Given this list of marker genes PLA2R1, KRT12, UGGT1, AGGF1, ZNF549, MALT1, LPAR3, EN2, APPBP2, XAB2, ZNF606, STS, CENPJ, HAND2, AGT, TULP2, DHX58, MAPK1, PIK3IP1 (phosphoinositide-3-kinase interacting protein 1), SPOCK3, KHDRBS2, MIER2, ACD, TMEFF1, GTF3C2, GK, C15orf39, TRIP4, ELAVL2, HAVCR1, TMOD3, RNASE2, TRMT2A, METTL13, EPS15L1, CUL9, PLEKHH3, SNX3, ERBB2, KIF16B, PPP2R3C, PANK4, DAPK3, LRRC2, CMKLR1, GRM4, PDZD7, ZNF140, NR1H2, CALY, PTPRG, NUP37, RUBCNL, RCC1L, UGGT2, NLGN1, UBAP2, MEGF6, KANK3, LTN1, ZSCAN12, BAG4, KNL1, AGXT (NCBI Gene Id 51432), FUT6, ARL8B, RAB40C, CAMK1D, ZNF250, AGO1, CD28, PARP8, MYNN, SMC6, MGAT4A, FBXO34, PRRX1, MTNAP1, CCN3, FAM53C, KIF21B, CDH1, PLN, ZNF408, CNIH1, ANGPTL8, HSPA14, KRT19, CALCR, MYH1, RASA1, COQ8B, KIF22, FAM118A (family with sequence similarity 118 member A), TOLLIP (toll interacting protein), PRPS2, APBA3, DNAJA2, ZNF134, PRCC, CTDP1, PNKP, SEPTIN7, SND1, PEX14, ARHGAP35, LDB2, MINDY1, EPYC, DNMT1, SOCS7, COL8A1, HS3ST3B1, RGL2, NT5C2, FBXO4, TIMM44, MMADHC, DCP2, KCNJ4, C1QB, SSX5, PLA2G2F, TRPC4AP, GNGT1, PARPBP, PEX6, TPD52, CCR6, MED18, KLHDC4, CLCA3P, C1orf54, GARNL3, RFC5, PARM1, ZGPAT, PMS2P4, C3AR1, CENPN, ATG9A, RAP1GDS1, CSNK2A2, CDK8, PPP4R4, LAPTM4A (NCBI Gene Id 9741), TBC1D12, SUV39H2, ACOXL, SEL1L, STK39, HERC2P3 (HERC2 pseudogene 3), SPTLC2, LMAN1, DCX (NCBI Gene Id 1641), LNPEP, SAP130 (Sin3A associated protein 130), HBS1L, RAP1B, PCGF2, STYK1, FOXN2, OCM2, DBNDD1, TRAIP, NEMF, PDZRN3, PRDM10, APOBEC3C, ABHD5, SOS1, RAPSN, SOX15, TKFC, GP2, EDIL3, PALB2, BRIX1, RAB5A, SUPT6H, AFG2B, PTBP1, EDC4, SECTM1, CYRIB, IL4, VAMP5, PLXDC1, POLR3C, SCN5A, GIMAP4, RFC1, DNAJC7, ASIP, MEN1, DHX38, BNIP2, EFNA4, here is a description of the gene set: from publication D'Cruz LM, Knell J, Fujimoto JK, Goldrath AW (PMID 20154672) Human Gene Set: GSE19923_WT_VS_E2A_KO_DP_THYMOCYTE_DN species: Homo sapiens Genes down-regulated in double positive thymocytes: wildtype versus TCF3 knockout. We wanted to test the role of mammalian E proteins E2A and HEB in the development of T cells. Using a conditional deletion system in which these proteins are deleted at the DP stage of T cell development, we compared DP thymocytes deficient for E2A, HEB or both to wild-type thymocytes